The following is a description of a gene set: studied in species Homo sapiens Thirty-eight PBMC samples from 25 patients with IPF and 13 matched controls yielded 149,564 cells that segregated into 23 subpopulations. Classical monocytes were increased in progressive and stable IPF compared to controls (32.1%, 25.2%, 17.9%, respectively, p<0.05). Total lymphocytes were decreased in IPF vs controls, and in progressive vs stable IPF (52.6% vs 62.6%, p=0.035). Tregs were increased in progressive vs stable IPF (1.8% vs 1.1% of all PBMC, p=0.007), although not different than controls, and may be associated with decreased survival (P=0.009 in Kaplan-Meier analysis; P=0.069 after adjusting for age, sex, and baseline FVC). Flow cytometry analysis confirmed this finding in an independent cohort of IPF patients. Fraction of Tregs out of all T cells was also increased in two cohorts of lung scRNA-seq. CCL22 and CCL18, ligands for CCR4 and CCR8 Treg chemotaxis receptors, were increased in IPF. The single-cell atlas of the peripheral immune system in IPF, reveals an outcome-predictive increase in classical monocytes and Tregs, as well as evidence for a lung-blood immune recruitment axis involving CCL7 (for classical monocytes) and CCL18/CCL22 (for Tregs). (From Abstract) from publication Unterman A, Zhao AY, Neumark N, Schupp JC, Ahangari F, Cosme C Jr, Sharma P, Flint J, Stein Y, Ryu C, Ishikawa G, Sumida TS, Gomez JL, Herazo-Maya JD, Dela Cruz CS, Herzog EL, Kaminski N (PMID 38717443) Genes upregulated in Dendritic cells from Idiopathic Pulmonary Fibrosis Patients vs. Controls Human Gene Set: UNTERMAN_IPF_VS_CTRL_DC_UP, and this is the list of marker genes: MT2A, VCAN, RPS4Y1, S100A12, S100A8